Given this list of marker genes Tecta, Ripor2, Scrib, Nherf1, Atp2b2, Rac1, Sec24b, Whrn, Clrn1, Ush1c, Myo7a, Slitrk6, Tprn, Rest, Myo3b, Pls1, Pdzd7, Mir96, Grxcr1, Cdh23, Ankrd24, Clic5, Pcdh15, Wdpcp, Sod1, Strc, Lhfpl5, Myo3a, Triobp, Grxcr2, Clrn2, here is a description of the gene set: Mouse Gene Set: GOBP_AUDITORY_RECEPTOR_CELL_MORPHOGENESIS species: Mus musculus Any process that alters the size or shape of an auditory receptor cell.